The following is a description of a gene set: Any process that activates or increases the frequency, rate or extent of signal transduction mediated by the MAPK cascade. studied in species Mus musculus Mouse Gene Set: GOBP_POSITIVE_REGULATION_OF_MAPK_CASCADE, and this is the list of marker genes: Cd36, Nox4, Laptm5, Grm4, Card9, Ptpn22, Crk, Cd84, Nqo2, Fpr2, C1qtnf3, P2rx7, Gsn, Ptprc, Chi3l1, Cracr2a, Epor, Cd81, Pde5a, Flt4, Ins2, Pik3r6, Wnt7a, Stk25, Tgfb3, Fgf4 (fibroblast growth factor 4), Sorbs3, Map4k1, Gfral, Esr1, Cdk10, Tlr4, Naip1, Rell1, Mfhas1, Trim12a, Igfbp4, Pde6h, Rassf2, Fgd2, Traf7, Pdgfb, Cripto, Src, Fgf7, Arrb1, Lamtor1, Dnajc27 (NCBI Gene Id 319948), Pik3cg, Dstyk, Cntf, Gab1, Tab1, Madd, Gsdme, Maged1, Crkl, Cxcr4, Ptk2b, Tbx1, Fgb, Stk39, Nrp1, Magi3, Kdr, Drd4, Nrxn1, Csf1r, Ccr2, Fgf6, Myh9, Chrna7, Ern1, Kit, Bmp4, Fgf22, Mt3, Agt (NCBI Gene Id 11606), Dusp15, Ksr2, App, Nox1, Vegfa, Ankrd6, Epo, Fgf9, Zeb2, Pdgfa, Sh3rf2, Traf6, Lamtor3, Fgf16, Ntrk2, Phb1, Pde8a, Dvl3, Cavin3, Ccl21d, Acta2, Map4k4, Ccn2, Hmgb1, Ngfr, Tlr6, Klb, Irak1, Cd40, Il6ra, Tlr3, Nod1, Cd4, Mst1r, Tek, Glipr2 (GLI pathogenesis-related 2), Hcrtr1, Mydgf, Kiss1r, Tnfrsf11a, Mturn, Htr2a, Egf, Lmnb1, Adrb3, Ripk1, Kiss1, Hgf, Lpar2, Tnfaip8l3, Ackr3, Spag9, Cd27, Npy5r, Abl1, Erbb3, Sash1, Robo1, Fermt2, Il1b, Ccl19-ps4, Arhgap8, Alkal2, Fgfr2, Pak1, Il34, Cartpt, Tmem106a, Prdx2, Ndrg4, Map2k1, Oprk1, Tlr9, Ccr1, Ryk, Hras, Ccl21a, Apela, Fzd7, Dusp22, Map3k12, Ccl21f, Fbxw7, Timp2, Ret, Angpt1, Nkd1, P2ry1, Ar, Drd2, Map3k4, Fgf2, Ajuba, Tnik, Map3k7, Phb2, Nod2, Tgfb1, Tgfb2, Ppia, Birc7, Spry2, Fzd5, Taok2 (TAO kinase 2), Klhdc10, Avpr1b, Pla2g5, Plcg2, Eif2ak2, Rapgef1, Casr, Prkcz, Ndst1, Hmgcr, Thpo, Myd88, Ptpn11, Raf1, Sox2, Gpr37, Lep, Epha8, Adra2c, Ccl19 (C-C motif chemokine ligand 19), Bcl10, Stk3, Muc20, Map3k5, Ager, Lif, Kitl, Jun, Naip2, Map2k7, Vangl2, Fgf15, Mapk8ip3, Rb1cc1, Ccl19-ps3, Jcad, Mapk8ip1, Akap12, Flt1, Lilra5, Ptpn1, Ntf3, Gdf15, Tff2 (NCBI Gene Id 21785), Gnai2, Cxcl12, Rell2, Dab2ip, Edn1, Prkcd, Epgn, Map2k6, Psen1, Sema4c, Gadd45a, Gadd45g, Sema7a, Epha4, Mos, Fgf17, Ccl21e, Fcgr2b, Fgf21, Ceacam1, Kl, Dsc2, Ins1, Shc1, Wnt4, Garem1, Pdcd10, Adrb2, Pdgfra, Abl2, Fgfbp3, Nampt, C1qtnf1, Pycard, Drd5, Hand2 (NCBI Gene Id 15111), Osm, Ccr1l1, Npnt, Unc5cl, Rit2, Ccr7, Lyn, Tpd52l1, Tenm1, Ntrk3, Nptn, Inava, Cd24a, Rap1b, Trim12c, Ccl3, Ccl21b, Gadd45b, Lpar1, Dvl2, Map4k2, Fgg, Mink1, Trim30d, Cx3cl1, Nrg1, Fshr, Trim5 (tripartite motif-containing 5), Arl6ip5, Cdon, Gdf6 (NCBI Gene Id 242316), Naip5, Iapp, Nek10, Pdgfd, Gas6, F2rl1, Gcg, Adra1b, Eda2r, Notch2, Alox12b, Mapkbp1, Tirap (toll-interleukin 1 receptor (TIR) domain-containing adaptor protein), Dennd2b, Ksr1, Apoe, Dhx33, Lrrk2, Jak2, Erbb2, Zfp622, Peli2, Fgf18, Fgf8, Prkca, Fcer1a, Prkce, Igfbp3, Pdgfrb, Trim30b, Calcr, Mapk8ip2, Igf2, Nrk (NCBI Gene Id 27206), Sh3rf3, Drd1, Cxcl17, Lamtor2, Or2at4, Ntrk1 (neurotrophic tyrosine kinase, receptor, type 1), Dusp19, Sod1, Ern2, Wnt16, Esr2 (estrogen receptor 2 (beta)), Bnip2, Trim30c, Il3, Gpr183, Mif, Iqgap3, Rps3, Nmnat1, Gpr37l1, Igfbp6, Adora2a, Fgfr3, Gpr101, Bmp2, Tlr2, Fgf23, Ctnnb1, Spi1, Lpar3, Ilk, Fgf5, Npy, Ighm, Iqgap1, P2ry6, Pik3r5, Ngf, Fzd4, Igf1, Erbb4, Sphk1 (NCBI Gene Id 66122), Rapgef2 (Rap guanine nucleotide exchange factor (GEF) 2), Grm5, Ltbr, Dixdc1, Tnfsf11, C1qtnf2, Prxl2c, Map3k10, Egfr, Itga1, Adam9, Efna1, Cdc42, Traf2, Htr2c, Fzd10, Bcar3, Taok3, Wnt7b, Adora1, Tpbg, Rock1, Grm1, F2r, Trem2, Ezh2, Rasgrp1, C3, Cd74, Fpr-rs6, Tgfa, Mapk3, Il1a, Fpr-rs3, Atp6v0c, Ntsr2, Adra2a, Map3k11, Tnf, Pja2, Trp73, Adam17, Insr, Nenf, Adra1a, Ccdc88c, Psap, Ripk2, Crhr2, Map3k3, Rnf13, Il11, Vegfb, Fzd8, Fgfr4, Lepr, Mid1 (NCBI Gene Id 637916), Gcnt2, Bmper, Naip6, Arrb2, Ednra, Adcyap1, Necab2, Cib1, Trpv4, Mef2c, Gper1, Wnt5a, Pdgfc, Fga, Axin1, Map2k4, Cflar, Fpr-rs4 (formyl peptide receptor, related sequence 4), Nelfe, Havcr2, Fpr-rs7, Dcc, Camk2d, Marco, Syk, Htr2b, Map2k3, Cd44, Myoc, Rap1a, Arhgef5, Dab2, Alox15, Gpr55, Fgf1, Npsr1, Pde6g, Map3k1, Serpinf2, Pten, Map3k13, Adrb1, Inhba, Ccl19-ps6, Adra1d (NCBI Gene Id 11550), Taok1, Bank1, Ddr2, Nodal, Edar, Dkk1, Ptprj, Ccl19-ps5, Rock2, Xdh, Frs2, C5ar1, Fgf10, Asb3, Ccl19-ps1, Wwc1, Slamf1, Zc3h12a, Dok4, Gpnmb, Ffar4, Mbip, Prok1, Lrp1, Pla2g2a, Icam1, Igf1r, Dok5, Cdh2, Met, Tnfrsf19, Sstr4, Ghrl, Ramp3, Oprm1, Gpr39, Xiap, Adam8 (a disintegrin and metallopeptidase domain 8), Asb15, Itgb3, Erp29, Traf4, Scimp, Ccnq, Clec7a, Fgf3, Gpbar1, Fgf20, Cspg4 (chondroitin sulfate proteoglycan 4), Kcnn4, Alkal1, Prkd2, Adra2b, Hipk2, Cav2, Fgfr1, Slc30a10, Sh3rf1, Pde8b, Edn3, Avpi1, Braf, Fgd4, Abca7, Plcb1, Lat, Cysltr2, Il6, Trim30a, Notch1, Thbs1